Given this list of marker genes TNFRSF4, PRR14, TSPAN9, ASIC4, TNFRSF1B, KCNK10, TP53AIP1, ABLIM1, PRPF38B, CCN5, GDPD3, GPSM2, CST1, GPR132, ZNF862, PCDH9, SKAP1, CNTN1, SETD1A, ACADS, GFRA3, NOL12, GABRA3, NCBP1, TNFAIP8, DNASE1L2, CCNL2, PSME3IP1, MFNG, PHF11, TSNAXIP1, DCP2, DAZAP2, SYMPK, ATAD5, ZNF652, RENBP, PRPF3, LY6G6E, EXOC3, TINF2, NGLY1, ZNF586, FZD9, ZNF266, CSGALNACT1, DUSP2 (dual specificity phosphatase 2), EPB42, ADRA1A, GNPAT, VPS37A, MIEF1, AEBP1, RSRP1, ZNF44 (NCBI Gene Id 7610), LGI2, TRAPPC14, TRAC, SPDEF, GATD3, NME8, PPWD1, GABPB1-IT1, PRPS1, C19orf73, TRIM68, ADA2, SLC25A44, FYN, SIKE1, POLR2C, INTS8, CLPS (NCBI Gene Id 1208), GPD1, PCNX1, CABP1, UQCC1, TM7SF2, CENPF, ZFR2, PGK2, SHMT1, BMP7, PIH1D1, MGMT, FGF3, BUB1B, MRPS22 (NCBI Gene Id 64953), GNAT2, SCN8A, NUP88, IPO8, CHRNB2, ACAD10, CACNA2D2, PGS1, ACO2, ACOX1, ALMS1, PRUNE1, PRPH, SPG11, KIF2A, NFYC, MKLN1, WAPL, SSTR1, NUDT1, SLC35E2B, ZMYM3, FAM76A, GLB1L2, NPRL2, VAMP4, BARD1, PRKCH, ZNF211, LAS1L (LAS1 like ribosome biogenesis factor), MTMR12, ZNF345, CDKL2, HADH, ATF7IP, PMVK, NOTCH1, GNAI2, IL6R, EXOSC1, MIS18A, UTP6, IKZF1 (NCBI Gene Id 55429), KIFC1, CASZ1, IFI16, GUCA2A, ZBTB43, BTG1, LRRFIP1, MTIF2, TEX10, ACAP1, CHST11, STAT5B, HOXB3, AKAP7, SDR39U1, AAGAB, FAAP24, C1QTNF3, SART1, KCNQ1, FSHR, SF3B1, ZBTB17, INF2, B3GNT3, AMN, HDAC1, BCOR, PCIF1, SMARCA4, XRCC2, CEP192, THOC1, SRSF4, L2HGDH, DUS2, SINHCAF, ALKBH4, IRF2, GALNT7, ZRSR2, NPAP1, PDK3, C8orf33, MYBPC2, SUCLG1, RS1, ISG20, LIME1, CENPC, ILKAP, NUBP2, KIF22, PAPOLG, SAFB, CA9 (NCBI Gene Id 768), RGL2, FGF18, MEF2A, ZNF587, WRAP73, SASH3, CEP72, CMTR1, here is a description of the gene set: Human Gene Set: GSE1460_DP_THYMOCYTE_VS_THYMIC_STROMAL_CELL_UP Genes up-regulated in comparison of CD4 CD8 thymocytes versus thymic stromal cells. from publication Lee MS, Hanspers K, Barker CS, Korn AP, McCune JM (PMID 15210650) studied in species Homo sapiens Subpopulations of human fetal thymocyte and circulating naïve T cells were obtained through FACS sorting, including CD3-CD4+CD8- intrathymic T progenitor cells (ITTP), CD3intCD4+CD8+ \double positive\ thymocytes (DP), CD3highCD4+CD8- \single positive\ thymocytes (SP4), CD3+CD4+CD8-CD45RA+CD62L+ naive T cells from cord blood (CB4+), and CD3+CD4+CD8-CD45RA+CD62L+ naive T cells from adult blood (AB4+).